Given this list of marker genes GAS1, ADH1B, FBLN1, CCN3, LSP1, CYP11B2, FOSB, WNT4, NR4A2, C3, AADAC, VSNL1, MFAP5, PDGFRA, IGFBP5, RARRES2 (retinoic acid receptor responder 2), SPON1, DCN, KCNQ1, HSD3B2, here is a description of the gene set: Top down-regulated genes in pediatric adrenocortical tumors (ACT) compared to the normal tissue. from publication West AN, Neale GA, Pounds S, Figueredo BC, Rodriguez Galindo C, Pianovski MA, Oliveira Filho AG, Malkin D, Lalli E, Ribeiro R, Zambetti GP (PMID 17234769) Human Gene Set: WEST_ADRENOCORTICAL_TUMOR_MARKERS_DN Pediatric adrenocortical tumors (ACT) are rare and often fatal malignancies; little is known regarding their etiology and biology. To provide additional insight into the nature of ACT, we determined the gene expression profiles of 24 pediatric tumors (five adenomas, 18 carcinomas, and one undetermined) and seven normal adrenal glands. Distinct patterns of gene expression, validated by quantitative real-time PCR and Western blot analysis, were identified that distinguish normal adrenal cortex from tumor. Differences in gene expression were also identified between adrenocortical adenomas and carcinomas. In addition, pediatric adrenocortical carcinomas were found to share similar patterns of gene expression when compared with those published for adult ACT. This study represents the first microarray analysis of childhood ACT. Our findings lay the groundwork for establishing gene expression profiles that may aid in the diagnosis and prognosis of pediatric ACT, and in the identification of signaling pathways that contribute to this disease. studied in species Homo sapiens